Given this list of marker genes ACTC1, NUTF2P6, TPST2P1, NUTM1, LINC02252, GJD2, HNRNPLP2, GOLGA8B, LARP4P, LINC02694, ANP32AP1, HNRNPA1P45, LINC02345, AVEN, LINC02853, CDIN1, DPH6-DT, MIR1233-2, COX6CP4, ENSG00000259737, THBS1-IT1, RBM17P4, ENSG00000259278 (NCBI Gene Id 105370781), LPCAT4, ENSG00000212511, MEIS2, LINC02895, MIR3942, EMC7, EMC4, ACTG1P15, GOLGA8A, DPH6, PGBD4, MIR1233-1, FSCN1P1, ZNF770, TMCO5A, DNM1P5, FAM98B, CHRM5, RASGRP1, MIR8063, TUBAP11, NOP10, MIR4510, KATNBL1, RPL32P2, AQR, PRELID1P4, SPRED1, CSNK1A1P1, SLC12A6 (solute carrier family 12 member 6), NANOGP8, GJD2-DT, THBS1, FSIP1, RPL36AP8, LINC01852, LINC02915, THBS1-AS1 (THBS1 antisense RNA 1), here is a description of the gene set: species: Homo sapiens Human Gene Set: chr15q14